The following is a description of a gene set: Mouse Gene Set: GOBP_POSITIVE_REGULATION_OF_CEREBELLAR_GRANULE_CELL_PRECURSOR_PROLIFERATION species: Mus musculus The process that activates or increases the rate or extent of granule cell precursor proliferation., and this is the list of marker genes: Shh, Gpr37l1, Igf1, Egf, Fgf2